The following is a description of a gene set: A ribonucleoprotein complex that contains small nuclear RNA U1, a heptameric ring of Sm proteins, as well as several proteins that are unique to the U1 snRNP, most of which remain associated with the U1 snRNA both while the U1 snRNP is free or assembled into a series of spliceosomal complexes. Human Gene Set: GOCC_U1_SNRNP species: Homo sapiens, and this is the list of marker genes: SNRPC, RNVU1-6, SNRPA, RNVU1-1, SNRNP70, WEE2-AS1, PRPF39, SNRPE, LUC7L2, RNVU1-2A, SNRPB2, SNRPD3, SNRPN, RNVU1-4, SNRPD2, SNRPGP15, PRPF40B, SNRPB, LUC7L, LUC7L3, SNRPG (small nuclear ribonucleoprotein polypeptide G), RNVU1-17, PRPF40A, RNVU1-3, SNRPF, RNVU1-14, RNU1-4, SNRPD1 (NCBI Gene Id 6632), RNVU1-8, RNVU1-7, RNVU1-15, RNVU1-19